The following is a description of a gene set: Mouse Gene Set: GOMF_HISTONE_H3K4_DEMETHYLASE_ACTIVITY Catalysis of the removal of a methyl group from a modified lysine residue at position 4 of the histone H3 protein. studied in species Mus musculus, and this is the list of marker genes: Riox1, Kdm5a, Kdm1b, Kdm1a, Riox2, Kdm5c, Kdm5d, Kdm5b